The following is a description of a gene set: Human Gene Set: GSE360_L_DONOVANI_VS_T_GONDII_MAC_DN Monocyte-derived dendritic cells (DC) and macrophages (MΦ) generated in vitro from the same individual blood donors were exposed to five different pathogens, and gene expression profiles were assessed by microarray analysis. Responses to Mycobacterium tuberculosis and to phylogenetically distinct protozoan (Leishmania major, L. donovani, Toxoplasma gondii) and helminth (Brugia malayi) parasites were examined, each of which produces chronic infections in humans yet vary considerably in the nature of the immune responses they trigger. Genes down-regulated in comparison of macrophages exposed to L. donovani versus macrophages exposed to T. gondii. from publication Chaussabel D, Semnani RT, McDowell MA, Sacks D, Sher A, Nutman TB (PMID 12663451) studied in species Homo sapiens, and this is the list of marker genes: PADI2, CCR7, GNB5, MRTFA, TRAP1 (NCBI Gene Id 51721), MGRN1, ACADS, NONO, CDH1, ZPR1, CCT7, AMPD2, COQ2, GNA11, MAPKAPK3, TELO2, SNED1, CHERP, CCT4, RUSC1, ALG3, STAG1, TUFM, TCF3, NDUFS3 (NCBI Gene Id 4722), NFYC, PC, SF1, PRMT3, SPINT2, SRP19, PFKP, REL, RCC1, MAPKAPK2, SHMT1, SECISBP2L, RAD9A, DNAJC11, MCM2, CDKN1C (cyclin dependent kinase inhibitor 1C), CCL11, KCNQ1, SCAP, TCERG1, AMHR2, TIMP3, FEN1, HAGH, THY1, CH25H, RBL1, INPP4B, MCF2L, TMEM147, PIEZO1, DLEC1, ARR3, GAA, GAL, MEP1B, CPT1A, TYMS, HSF1, FLII, PLCB1, ST3GAL5, UQCRC1, FASN, RFC4, OVOL3, SNRPD2, POLD2, HGS, ZWINT, FADD, FKBP9, SCARB1, MCCC2, IER2, SAC3D1, ARHGAP22, FAM13A, MUC6, GNA15, SPINK4, MRPL12, AOPEP, BBLN, PTPRCAP, ZBTB24, TYMP, POLR2H, NAA10, NAP1L4, SLC43A1, ILF3, CPNE1, SCN9A, IGFBP4, GAK (cyclin G associated kinase), PABPC4, MX1, NRG1, INPP5A, RALY, SNRPF, AIMP2, SIVA1, PDE1A, INPP5B, PYGM, BIRC5, NME4, CPOX, IL15RA, TPM4 (tropomyosin 4), METAP1, UCK2, TEX30, RCN2, SRRD, KPNA2, BYSL, LRRFIP1, SLC37A4, TIMM44, REM1, PSMG1, EZR, PHLPP1, MEN1, SMURF1, SAFB, RASSF1, MED13L, EZH2, PLAU, PRDX2, DNAJC9, POLR2I, EEF1B2, PURA, RPL13P5, STAT4, MRPL23, HRAS, SEL1L3, GAS6, LPAR2, AFG3L2, KIF1B, PMAIP1, AATF, CEACAM7, FAM3A, ACP1, RAB33A, TLE1, IRF7, GSTZ1, TARBP2, PPFIA4, LAGE3 (L antigen family member 3), RANBP2, SNRPA, ACD, RRAS2, PRKN, IQSEC2, H3C11, CASP7, SGTA, ACTN1, TRAF5, AASS, SCGN, HEG1, PBX2 (NCBI Gene Id 5089), CREM, NIT1, RIN1, LCOR, NHP2, TFAP4, DGAT1, ANK1, ODC1, TOMM34, ABCD2, H2AZ2, ATXN2, FDPS, ADRM1, NMB, HPCAL1, NCK2 (NCK adaptor protein 2), PEX5, GBF1, ALDH1A2